Given this list of marker genes Rnf10, Fas, Dicer1, Pmp22, Ctnnb1 (catenin beta 1), Ascl2, Nrg1, Ski, Sox10, Nf1, Gfap, Nf2, Cers2, here is a description of the gene set: Mouse Gene Set: GOBP_SCHWANN_CELL_PROLIFERATION studied in species Mus musculus The multiplication or reproduction of Schwann cells, resulting in the expansion of their population. Schwann cells are a type of glial cell in the peripheral nervous system.